The following is a description of a gene set: The migration of a T cell from the blood vessels into the surrounding tissue. studied in species Homo sapiens Human Gene Set: GOBP_T_CELL_EXTRAVASATION, and this is the list of marker genes: FADD, ICAM1, RIPK3, CRK, CD99, IL27RA, XG, F11R, MED23, ITGAL, CD99L2, CRKL, CCL2, CCR2